The following is a description of a gene set: studied in species Mus musculus Mouse Gene Set: GOBP_LATE_ENDOSOME_TO_GOLGI_TRANSPORT The directed movement of substances from late endosomes to the Golgi., and this is the list of marker genes: Snx3, Rab7b, Sgsm2, Ap5z1, Gcc2, Snx12